The following is a description of a gene set: species: Mus musculus Any process that stops, prevents, or reduces the frequency, rate or extent of the chemical reactions and pathways resulting in the formation of fatty acids. Mouse Gene Set: GOBP_NEGATIVE_REGULATION_OF_FATTY_ACID_BIOSYNTHETIC_PROCESS, and this is the list of marker genes: Acadl, Erlin1, Trib3, Acadvl, Apoc3, Dcaf5, Ceacam2, Sirt1, Cyp7a1, Klhl25, Insig2, Apoc1, Pibf1, Ubr4, Brca1, Ceacam1, Erlin2, Insig1, Wdtc1